Given this list of marker genes DCP1B, LSM3, DDX6, LSM1, XRN1, LSM7, DCP1A, LSM6, EDC4, EDC3, PATL1, LSM5, LSM4, DCP2, LSM2, here is a description of the gene set: mRNA decay by 5' to 3' exoribonuclease Human Gene Set: REACTOME_MRNA_DECAY_BY_5_TO_3_EXORIBONUCLEASE studied in species Homo sapiens